The following is a description of a gene set: This SuperSeries is composed of the SubSeries listed below. studied in species Homo sapiens from publication Walker LJ, Kang YH, Smith MO, Tharmalingham H, Ramamurthy N, Fleming VM, Sahgal N, Leslie A, Oo Y, Geremia A, Scriba TJ, Hanekom WA, Lauer GM, Lantz O, Adams DH, Powrie F, Barnes E, Klenerman P (PMID 22086415) Human Gene Set: GSE33425_CD161_HIGH_VS_NEG_CD8_TCELL_UP Genes up-regulated in CD8 T cells: KLRB1 high versus KLRB1-., and this is the list of marker genes: UBE2O, MGP, MARS1, HIRA, RNGTT, CTSG, DNMT1, TLE4, KDM5B, GPD2, MEF2C, FLCN, ILVBL, RAB3IP, CSK, ZNF143, ADA, GCNT1, MCM6, SIPA1, BCL6, SKIL, LGALS9B, CTR9, DARS1, STX1A, POLA1, SERAC1, STK11IP, CCR6, ANKRD2, UHRF1, SSBP2, MLX, BTG1, ADPRM, RAB21 (NCBI Gene Id 23011), PADI3, HLA-DRB1, PARP1, VASP, MARK2, WDHD1, RFC1, PARP8, SMPD1, PDE7A, BMAL1, REXO1, TMEM109, POLD1, HYAL2, CDT1 (NCBI Gene Id 81620), MPHOSPH9, NPTX1, HDAC1, GABBR1, TNIP1, TAX1BP1, VAV1, RTTN, COL11A1, HSD11B1, MCM3AP, CD72, ATG16L1, BTBD3, PAN2, PTP4A3, SUPT5H, IRF8, CENPB, ARHGAP39, SFT2D1, AP2S1, CXXC1, CAP1, RALB, ARHGAP45, LGMN, PSTPIP1, MEIG1, PCID2, SSTR4, AMBP, ADRB2, RRM2, HES3, NR4A2, SLC9B2, EIF4G2, GSN, C8G, SLC17A1, PTPN6, TBC1D1, FZD9 (NCBI Gene Id 8326, frizzled class receptor 9), SIX4, ANKFY1, GDF5, CFB, HHEX, NDST2 (NCBI Gene Id 8509), TRIP12, HSD3B7 (hydroxy-delta-5-steroid dehydrogenase, 3 beta- and steroid delta-isomerase 7), TRIM47, SMAD7, RBM4B, SLC22A5, NXPH1, EIF2B4, RASA4, LTA, AURKA, IFIT3, OTUB1, CAPN5, RAD52, DPP3, IER2, VSX2, GYS1, ETV2, STRADA, HTR1B, CTSA, SORL1, SIN3A, BCL2 (BCL2 apoptosis regulator), CENPA, JARID2, ITPKB, ID3, PBX1, CIITA, RPS6KA2, PI4K2A, HBA2, NFKBIA, LDHB, EMID1, MYB, FUBP1 (NCBI Gene Id 8880), TNFAIP8L1, GADD45A (NCBI Gene Id 1647), HLA-DQA1, F2RL1, CUX2, HAUS5, RFLNB, F8A1, FYN, SELL, PER2, OGFOD2, POLDIP3, CSAD (cysteine sulfinic acid decarboxylase), SLC30A5, IL16, CDH2, BSDC1, SNX5, SELENOH, NOCT, NUP50, RHOG, GPD1, PPM1B, SATB1 (SATB homeobox 1), CPN1, TNFRSF21, IL10RA, HLA-DMB, SLC44A2, LARP7, IRF5, SLC30A4, PROP1, PXK, CGGBP1, ITM2A, INSIG1, DDB1, PER1, TAF8, DLX3 (distal-less homeobox 3), GAD1, PRPH2, USP38, FRAT2, CPSF7, ACRBP (NCBI Gene Id 84519), TRAPPC5, CNN3, SMC2, PLD3, UQCRC1, FOXRED1, CHFR